The following is a description of a gene set: studied in species Mus musculus Mouse Gene Set: GOBP_PHENOL_CONTAINING_COMPOUND_BIOSYNTHETIC_PROCESS The chemical reactions and pathways resulting in the formation of a phenol, any compound containing one or more hydroxyl groups directly attached to an aromatic carbon ring., and this is the list of marker genes: Kl, Slc45a2, Slc24a5, Opn3, Ddt, Mfsd12, Slc7a11, Crhr2, Zeb2, Fev (FEV transcription factor, ETS family member), Snca, Pnmt, Wnt5a, Mc1r, Dao, Tph1, Appl1, Tph2, Agtr2, Th, Tyr, Myo5a, Cdh3, Moxd1 (NCBI Gene Id 74332), Vps35, a, Aldh2, Gch1, Epas1, Tgfb2, Oca2, Dct, Insm1, Park7, Gata3, Gipc1, Atp7a, Agtr1a, Cited1, Hand2, Rab38, Ctns, Nr4a2, Trpc1, Tyrp1, Ddc, Pmel, Hdc, Gpr37 (NCBI Gene Id 269834), Slc6a3, Rapgef2, Dbh, Moxd2, Cyp2d22